The following is a description of a gene set: species: Mus musculus Mouse Gene Set: WP_FAS_PATHWAY_AND_STRESS_INDUCTION_OF_HSP_REGULATION FAS pathway and stress induction of HSP regulation, and this is the list of marker genes: Pak2, Bcl2, Rb1, Fas, Daxx, Pak1, Il1a, Parp1, Casp6, Dffa, Casp9, Arhgdib, Mapkapk3, Dffb, Tnf, Apaf1, Ripk2, Map3k7, Lmnb2, Prkdc, Casp8, Casp7, Ptpn13, Lmnb1, Map2k4, Casp3 (NCBI Gene Id 12367), Cflar, Hspb1, Faf1 (NCBI Gene Id 99976), Sptan1, Mapk8, Mapkapk2, Jun, Map3k1, Lmna, Fasl